The following is a description of a gene set: studied in species Homo sapiens Any process that modulates the frequency, rate or extent of microglial cell activation. Human Gene Set: GOBP_REGULATION_OF_MICROGLIAL_CELL_ACTIVATION, and this is the list of marker genes: MIR128-1, CTSC, LDLR, CST7, SYT11, TTBK1, CX3CL1, CALHM2, NR1D1, IL6, GRN, STAP1, TAFA3, MIR142, TREM2, CCL3, SPHK1, PTPRC, LRRK2 (leucine rich repeat kinase 2), MMP8